The following is a description of a gene set: Genes down-regulated in B lymphocytes stimulated by anti-IgM for 16h: wildtype versus NFATC1 knockout. Human Gene Set: GSE21063_WT_VS_NFATC1_KO_16H_ANTI_IGM_STIM_BCELL_DN studied in species Homo sapiens from publication Bhattacharyya S, Deb J, Patra AK, Thuy Pham DA, Chen W, Vaeth M, Berberich-Siebelt F, Klein-Hessling S, Lamperti ED, Reifenberg K, Jellusova J, Schweizer A, Nitschke L, Leich E, Rosenwald A, Brunner C, Engelmann S, Bommhardt U, Avots A, Müller MR, Kondo E, Serfling E (PMID 21464221) Triggering of B cell receptors (BCR) induces a massive synthesis of NFATc1 in splenic B cells. By inactivating the Nfatc1 gene and re-expressing NFATc1 we show that NFATc1 levels are critical for the survival of splenic B cells upon BCR stimulation. NFATc1 ablation led to decreased BCR-induced Ca++ flux and proliferation of splenic B cells, increased apoptosis and suppressed germinal centre formation and immunoglobulin class switch by T cell-independent antigens. By controlling IL-10 synthesis in B cells, NFATc1 supported the proliferation and IL-2 synthesis of T cells in vitro and appeared to contribute to the mild clinical course of Experimental Autoimmune Encephalomyelitis in mice bearing NFATc1-/- B cells. These data indicate NFATc1 as a key factor controlling B cell function., and this is the list of marker genes: PDE8B, MAGEB2, MED15P9, HAVCR2, OR6W1P, FRZB, SGCD, PDGFRB, UAP1, TTC38, DAB2IP, SLC26A8, PCDHGA10, GJA1, PCDHGA9, EPCIP, SLC8A1, MYO6 (NCBI Gene Id 4646), DRC7, LINC02297, LRRC4C, DEFB121, ATP13A4, PCDH1, LINC02693, CHST2, TEX55, KIF2B, TLL2, PRSS40A, CENPO, CTSLP8, DUSP19, PTPN12, SFTA3, BBC3, CDC25A, KRT78, GLI2, ITGB8, SPP2, ASIC3, BTN1A1, DKK2, LINC01686, RNF130, GOLM1, TMPRSS12, PAX9, MROH2B, TM4SF4, RAB17, JAZF1, RFX6 (NCBI Gene Id 222546), PGA3, LINC00917, PGAM1, MOCS1 (NCBI Gene Id 7931), SATB2 (NCBI Gene Id 80104), ADRB2, MAB21L4, ACTG1P17, SERTAD3, TMED9, B3GAT1, CAMK2N1, ITGB7, ARMC9, SIGLEC9, SIGLEC6, TGM5, PALLD, CHRDL1, DNAH10, KRT2, RGS9, ADGRG1, NPVF, CTNNA1, SMYD4, GZMH, SPINDOC, FRMD4B, UBE2U, TLE1, MIR770, CLDN14, FAM199X, UNC13A, GAD2, LRP2, PCSK1, FGFBP2, COPZ2, FAR2P2, CXCR2, IGLL1, STAT3, EPHB3, HDC, CXCR1, RTN4, RAB27B, C1QTNF7, EDIL3, NFIL3, SIK2, ST8SIA2, TOR4A (torsin family 4 member A), CFAP57, TSPAN9, SLC5A5, SIX3, SMIM14, RASSF4, SUSD1, CMKLR1, WBP2NL, CORO1C, ANKRD30B (NCBI Gene Id 374860), SPON2, PRSS23, TINAG, ZNF528-AS1, GZMB, CST4, KRT222, GNAL, SEMG2, MED18, IFNA14, ADH1B, SEMA3B, RHOBTB3, PIGS, MAGEF1, LGR6, GPBAR1, CNGB1, ASCL2 (achaete-scute family bHLH transcription factor 2), LIM2 (NCBI Gene Id 3982), C10orf71, KIF13A, PCDHGB5, SLC15A4, F11R (F11 receptor), PTCH1, CX3CR1, SLC38A7, GAGE1, RAB22A, SLCO4C1, MIR4453HG, OR51B4, CD3G, HAO1, CECR2, GLI3, KAAG1, NINL, ERBB2, MLC1, RBFOX2, IL20, KIRREL3, PRPF18, MEP1B, RAP2A, CCDC69, MAPRE2, CD68, DUXAP9, IFIT3, ATP10A, POMP, CSMD2, TSPAN8, CCDC140, NR0B1, SPINK5, S1PR5, ANXA4, GRP, CST7, MTSS1, HOXD3, PLD1, CACNA2D1